Given this list of marker genes CRYAB, BFSP2, BFSP1, HSPB2, CRYBB3, CRYGD, LIM2, CRYGC (crystallin gamma C), CRYBA2, CRYGA (NCBI Gene Id 1418), CRYBA4, CRYBB2, CPOX, CRYGB, CRYBG3, VIM, CRYGS (crystallin gamma S), CRYBA1, CRYGN, HSPB6, MIP, CRYAA, CRYBB1, here is a description of the gene set: Human Gene Set: GOMF_STRUCTURAL_CONSTITUENT_OF_EYE_LENS The action of a molecule that contributes to the structural integrity of the lens of an eye. species: Homo sapiens